The following is a description of a gene set: species: Homo sapiens Human Gene Set: GOBP_ACTIN_FILAMENT_DEPOLYMERIZATION Disassembly of actin filaments by the removal of actin monomers from a filament., and this is the list of marker genes: CAPZA3, VILL, TMOD2, TMOD4, MICAL1 (NCBI Gene Id 64780), F2RL1, SPTBN5, WDR1, SPTAN1, LMOD2, WASHC2C, SPTA1, DMTN, ADD2, CARMIL1, CFL2, ASB2, CFL1, PDXP, PLEK, ADD3, DSTN, VIL1, CARMIL2, SPTBN1, AVIL, PPP1R9B, PIK3CA, MICAL3, SPTB, MTPN, SWAP70, FLII, PLEKHH2, SPTBN4, CRACD, SPECC1L, SEMA5A, CAPZA2 (NCBI Gene Id 830), ACTN2, SH3BP1, TWF2, RDX, LMOD1, GSN, TWF1 (twinfilin actin binding protein 1), LIMA1, MICAL2, SCIN, TRIOBP (TRIO and F-actin binding protein), TMOD3, CAPZA1, LMOD3, TMOD1 (tropomodulin 1), SPTBN2, EPS8, ADD1, CAPG, CAPZB, SVIL